The following is a description of a gene set: studied in species Mus musculus Mouse Gene Set: MIR_15B_5P from publication Chen Y, Wang X (PMID 31504780) Genes predicted to be targets of miRBase v22 microRNA mmu_miR_15b_5p in miRDB v6.0 with MirTarget v4 prediction scores > 80 (high confidence targets)., and this is the list of marker genes: Sgk1, Srpra, Usp15, Hoxa10, Atp2b2, Ccdc6, Prkar2a, Cops7b, Ist1, Reck, Tbl1xr1, Smad7, Rfx3, Zfp449 (zinc finger protein 449), Abl2 (NCBI Gene Id 98214), Nol4l, Qki, Ppm1e, Ccnjl, Amotl1, Atp1b4, Usp42 (NCBI Gene Id 76800), Polr3f, Plxnc1, Chek1, Nrbp1, Dcaf7, Usp9x, Actr2, Xpo7, Arfgap2, Plekhh1, Nos1, Ppp1r11, Cc2d1b, Lhx3, Kif5b, Rab11fip1, Slc4a7, Pacsin2, Usp31, Kl, Scoc, Tmem87b, Dcp1a, Lrig2, Phip, Spag7, Nectin1, Lrrc32, Mfn2, Fbxw7, Spred1, Ubn2, Ube4b, Itpr1, Pik3r1, Sall4 (spalt like transcription factor 4), Setd3, Ankrd46, Krtap26-1, Tmem74b, Atxn2, Kcnq5, Phf20, Cntnap1, Lrp6, Cdca4, Dll1, Ptpn4, Rubcnl, Ghr, Atxn1l (NCBI Gene Id 78838), Colq, Tacc1 (NCBI Gene Id 78791), Gpatch8, Rictor, Nynrin, Klc1, Ints6l, Ttll6, Suco, Gcc2, Rnf10, Tuba4a, Sec14l1, Btbd8, Raf1, Slc39a10, Bicd1, Adgrl2, Slc7a2, Rab10, Bcl2l2, Abhd13, Rere, Cdk5r1, Slc6a11, Arhgdia, Ythdc1, Arhgap12, Ezh1 (NCBI Gene Id 14055), Fbln5, Rasgef1b, Helz, Smim13 (small integral membrane protein 13), Fstl1 (follistatin-like 1), Selenoi (selenoprotein I), Dennd10, Iars1, Ppp6c, Ccr2, Nrn1, Lats1, Caprin1, Ago1, Wbp11, Klhl2, Tab3, B3gnt6 (UDP-GlcNAc:betaGal beta-1,3-N-acetylglucosaminyltransferase 6), Rubcn, Plagl1 (pleiomorphic adenoma gene-like 1), Insyn2a, Sez6l, Wipi2, Fasn, Tenm2, Atf6, Zfhx3, Cpeb2, Dixdc1, Nfe2l1, Csrnp1, Ash1l, Ippk, Lurap1l, Aar2, Atxn7l3, Mob3b, Fbxo21, Avl9, Sptbn2, Plekhm3, Kmt2a, Apln, Mob4, Wee1, Adamts3, Nfatc3, Sall1, Clspn, Trank1, Slit2, Rfc1, Zfhx4, Desi1, Cmpk1, Onecut2, Fgf7, Arl2, Islr, Ppm1d, Tgfbr3, Kctd8, Tmcc1, Adissp, Pnoc, Ell, Cdk12 (NCBI Gene Id 69131), Jarid2, Vegfa, Cacul1, Cd2ap, Mkks, Bace1, Acvr2b, Igf2r, Aff4, Adrb2, Shoc2, Mapkap1, Lrig1, Kdsr, Hectd1, Slc4a4, Mmd, Son, Ddx3x, Cpsf7, Gm5460, Cert1, Slc25a22, Tbp, Atg14, Rbm6 (NCBI Gene Id 75102), Med1, N4bp1, Eif3a, Dnajc16, Sox6, Anks1, Zfp622, Zmym2, Usp12, Il10ra, Phc3, Spsb4, Cobll1, Dync1li2, Syde2, E2f7, Cpd, Htr4, Myt1l, Slc4a8, Wnt7a, Prmt6, Slc13a3, Seh1l, Fam151b, Kbtbd2, Pip4p1, Ywhah, Ube2q1, Pip4p2, Wnk3, Pnp2, Dsel, Slc20a2, Idh3a, Cbx6, Atp7a, Tmem178b, Capns1, Chac1, Ccnt2, Phf19, Ccne1, Akt3, Med26, Il7r, Kif5c (kinesin family member 5C), Prrc2c, Higd1a, Chd2, Pwwp2b, Etnk1, Rad23b, Kif21a, Capn6, Angel1, Rreb1, Krtap11-1, Acsl4, Gbp2b, Cdk17, Luzp1, Nup210, Ccdc85b, Zbtb44, Entpd7 (NCBI Gene Id 93685), Stxbp3, Plxna2, Wnt3a, Zcchc3, Tlk1, E2f3, Cldn12 (NCBI Gene Id 64945), Unc80, Cfap45, Kif23 (NCBI Gene Id 97568), Erc2, Ncapg2, Klc4, Capza2, Cpeb3, Sik1, Kif1c, Acvr2a, Rnf217, Bcl2, Akap7 (A kinase anchor protein 7), Pappa2, Fmn2, Tfap2a, Spryd3 (NCBI Gene Id 223918), Kcnj2, Usp14, Dll4, Pla2g15, Prdm4, B4galt1 (NCBI Gene Id 99960), Fgf9, Sel1l3, Plxna4, Casr, Smurf1, Gm12886, Ptprr, Pskh1, Plcxd2, Cyp26b1, Nup50, Cnot6l, Znrf2, Sesn1, Myb, 6430571L13Rik (RIKEN cDNA 6430571L13 gene), Axin2, Usp25, Akap11, 1700025G04Rik, Rnf144b, Epha7, Wwp1, Armh4, 2810459M11Rik, G0s2, Socs6, Nlrx1, Ncs1, Hmga1, Grm7, Ankrd13b, Drd1, Sema6d, Plpp1, Ubfd1, Abtb2, Trabd2b, Ptpn3, Sema3a, Fermt2 (fermitin family member 2), Bmpr1a, Rarb, Ano3, Rab9b (NCBI Gene Id 319642), Cacna2d1, Pam, Nuak2, Slitrk6, Ahcyl2 (NCBI Gene Id 74340), Zfp367, Traf3, Zswim3, Pappa (NCBI Gene Id 71487), Cdc37l1, Septin2, Gpr63, Hephl1, Kcnn4, Rad9a, Eda, Phactr2, Sec24a, Kpna1, Arih1, Fam135a, Clock (clock circadian regulator), Man2a2, Nudt4, Trp53inp2 (NCBI Gene Id 68728), Zfp275, Pdxk, Chpt1, Peli3, Cbfa2t3, Crebl2, Dclk1, Ccnd2, Kif1b, Ski, Mex3c, Zbtb34, Rasef, Tll1, Cdc25a, Hus1, Slc25a37, Pnpla6, Nav1, Ppp2r1b, Hapstr1, Zfp809, Pth, Satb2, Btrc, Ret, Crebrf, Tcaim, Btg2 (NCBI Gene Id 98237), Reln, Sec61a1, Zbtb39, Hectd4, Col12a1, Rspo3, Erlin2, Mgat4a, Stradb, Cbx4, Mybl1, Map2k1, Ago4, Omg, Armcx6, Adgrl1, Tbpl1, Pafah1b1, Eya1, Tnrc6b, Nufip2, Zyx, Garem1, Nudt7, Kcnk10, Penk, Ubr3, Pou2f1, Zfp300, Pex13, Tmem135